The following is a description of a gene set: from publication Pearce EL, Walsh MC, Cejas PJ, Harms GM, Shen H, Wang LS, Jones RG, Choi Y (PMID 19494812) Genes up-regulated in comparison of wild type CD8 effector T cells at day 6 versus those at day 10. Human Gene Set: GSE15750_DAY6_VS_DAY10_EFF_CD8_TCELL_UP CD8 T cells play a crucial role in immunity to infection and cancer. They are maintained in constant numbers, but upon stimulation with antigen undergo a developmental program characterized by distinct phases encompassing the expansion and then contraction of antigen-specific populations, followed by the persistence of long-lived memory cells. Although this predictable pattern of a CD8 T cell response is well established, the underlying cellular mechanisms regulating the transition to memory remain undefined. Here we show that TRAF6, an adapter protein in the TNF-receptor (TNFR) and IL-1R/TLR superfamily, regulates CD8 T cell memory development following infection by modulating fatty acid metabolism. We show that mice with a T cell-specific deletion of TRAF6 mount robust primary CD8 T cell effector responses, but have a profound defect in their ability to generate memory. This defect is CD8 T cell intrinsic and is characterized by the disappearance of antigen-specific cells in the weeks following primary immunization. Microarray analyses revealed that TRAF6-deficient CD8 T cells from early timepoints following immunization exhibit altered expression of genes that regulate fatty acid metabolism. Consistent with this, activated CD8 T cells lacking TRAF6 are unable to upregulate mitochondrial β-oxidation in response to growth factor withdrawal in vitro. Treatment with drugs that induce fatty acid oxidation enabled CD8 T cell memory generation in the absence of TRAF6. Remarkably, these treatments also increased CD8 T cell memory in wild type mice, and consequently were able to significantly improve the efficacy of an experimental anti-cancer vaccine. species: Homo sapiens, and this is the list of marker genes: CENPH, RAD54B, PCLAF, DEPDC1, MAP1LC3B, KIF23, SPC25, LRR1, NCAPG, KIF2C, CENPN, MXD3, SKA3, CIP2A, YWHAH, CDKN3, MCM5, MCM2, CENPA, CENPS, CDC6, PIMREG, SLIRP, CKS1B, MAD2L1, NSL1, CDC20, DIAPH3, HASPIN, PRC1, NDC80, CD109, IDI1, NEK2, UQCRFS1, SPC24, PMM1, VIM (vimentin), PARPBP, ASPM, ESD, SHCBP1, PGK1, RNASEH2B, DSCC1, CDC25C, AURKB, FAM229B, ARHGAP11A, RAD51B, TCF19, NEIL3, HROB, TTK, RAD54L, DHFR, LSM12, FAM83D, HELLS, FBXO33, CENPP, PMCH, TK1, RAD51AP1, CDCA8, GINS1, MED7, SNAP29, POLQ, FIRRM, NUF2, ACADL, KNTC1, PCYT1B, SENP1, UHRF1, BIRC5, STMN1, MT2A, GTSE1, NCAPH, AIPL1, HYLS1, SGO2, KPNA2, MELK, SMC2, SGO1, IQGAP3, PSMD1, BRCA1, PPIL1, LZIC, SPDL1, GLRX (glutaredoxin), TRIM66, CENPW, CDC45, TXN, RRM2, PSMG4 (proteasome assembly chaperone 4), RAD51, ESPL1, GINS2, MRPL9, ATAD5, SLAMF7, ANP32B, KIF11, CREB3L1, CENPM, ESCO2, CEP55, RIPK1, NUSAP1, FEN1, PIH1D2, PBK, CTNNAL1, KIF20A, MCM7, SKA2, FAS, TSPAN32, PAFAH1B2, SPAG5, TUBA1B, UBE2C, CCNB2, FBXO5, TIPIN, SRL, PRR11, CD2BP2, TOP2A, CKAP2L, OIP5, CENPE, SUMF1, RACGAP1, RBBP8, E2F7, VDAC3, MCM10, KNL1, PTPRK, CKAP2, ITGB1BP1, CHIT1, CDK1, BPNT2, CKS2 (CDC28 protein kinase regulatory subunit 2), KIF22, DYNLT1, SPAG1, RRM1 (ribonucleotide reductase catalytic subunit M1), MYBL2, IDH3A, KNSTRN, AURKA, CASP3, FIGNL1, POLA1, IAH1, STMN2, HNRNPAB (NCBI Gene Id 3182), CPPED1, PLEK (NCBI Gene Id 5341), NEURL1B, DBF4, DNA2, ASF1B, HMMR, PASK, SKA1, KIF18B (NCBI Gene Id 146909), BEX3, BUB1, LIG1, TPX2, FHL2, BUB1B, TAX1BP3, STIL, DCUN1D1, PRDX4, ZGRF1, CENPI, MUC20, POGLUT3, PLK1, NSD2, RPS27L, ALDH7A1, GMNN (geminin DNA replication inhibitor), MYBL1, C12orf75, AUNIP, ARPC5, RPA3